Given this list of marker genes DNHD1, BRWD1, CFAP45, SPACA1, IFT74, SSX1 (NCBI Gene Id 6756), CYLC1, WDR19, TEKT3, DRC1, DNAH10, DNALI1, ARMC12, USP26, AKAP3, STK33, DNAH7, LRRC23, RPL10L, FBXO43, CCIN, CFAP61, CCDC146, here is a description of the gene set: A reduced proportion of sperm that move in a straight line or large circles; alternatively, an increased proportion of sperm that move in tight circles or in some other non-linear fashion. Reduced progressive sperm motility Human Gene Set: HP_REDUCED_PROGRESSIVE_SPERM_MOTILITY studied in species Homo sapiens